The following is a description of a gene set: part of: Inositol phosphate metabolism species: Mus musculus This event has been computationally inferred from an event that has been demonstrated in another species.<p>The inference is based on the homology mapping from PANTHER. Briefly, reactions for which all involved PhysicalEntities (in input, output and catalyst) have a mapped orthologue/paralogue (for complexes at least 75% of components must have a mapping) are inferred to the other species. Reactome Pathway: IP6 and IP7 transport between cytosol and nucleus electronically inferred by orthology from the curated human pathway, and this is the list of marker genes: Aaas, Nup155, Seh1l, Rae1, Nup42, Nup205, Nup54, Nup85, Ndc1, Nup93, Nup210, Nup133, Nup58